Given this list of marker genes TREM2, CHMP2B, PIDD1, GM2A, VCP, TYROBP, GRN, PRKAR1B, PSEN1, MAPT, SQSTM1, DCTN1, VPS13A, TMEM106B, here is a description of the gene set: studied in species Homo sapiens Inappropriate behavior An explicit or perceived action, demonstration, conduct, or language (verbal and written) that is contrary to generally accepted norms, rules, procedures, or unacceptable within the context in which it is carried out. Inappropriate behaviors could take place in a sexual or social context and could be aggressive, violent, impulsive, intimidating, or threatening in nature. Human Gene Set: HP_INAPPROPRIATE_BEHAVIOR